The following is a description of a gene set: studied in species Homo sapiens Conversion from APC/C:Cdc20 to APC/C:Cdh1 in late anaphase Human Gene Set: REACTOME_CONVERSION_FROM_APC_C_CDC20_TO_APC_C_CDH1_IN_LATE_ANAPHASE, and this is the list of marker genes: UBE2C (NCBI Gene Id 11065), ANAPC16, ANAPC2, ANAPC11, UBE2D1, UBE2E1, CDC20, ANAPC5, ANAPC1, CDC23, CDC26, ANAPC15, UBE2S, ANAPC10, ANAPC4, CDC27, FZR1, CDC16, CDC14A, ANAPC7